Given this list of marker genes CDK2AP1, STAU2, TLCD3A (NCBI Gene Id 79850), MGAT4B, FARP1, MRAP, SNHG11, MAGEL2, FAM83D, SPATS2 (NCBI Gene Id 65244), ABCA12, POLR3D, MAZ, IDH2, MIXL1, NDUFB10, C2CD2L, TACC1, FBXL7, SLC26A11, KIF2C, MYH7, SLX4, SYT13, SMTN, NUCB2, CDCA8, GPT, GCGR, MEGF11, METRN, SSBP4, PRC1, SEMA3C, CRIP2, TTL, BEND6, PPIL1, ZG16, LSM14B, MGP, RACGAP1, PHPT1, NCAPH2, LRP5, KRT16, ZMYND11 (zinc finger MYND-type containing 11), ZC3H4, PPP1R13L, MCM10, RAB3A, AQP4, PIK3R2, ADGRA2, MAPK8IP1, CSNK1E, STARD4, CSDC2, DIP2C (disco interacting protein 2 homolog C), CORO6, GOLM2, RYK, STIMATE, TRABD, CIZ1, TACC3, INSIG1, TMED2, PLEKHG5, RCN3, MYBL2, CAV2, CDC42EP5, KIF22, MLPH, DNAJB13, MYLK3, NCOR2, FBXL19, CCNF, PTPRU, PHB2, TSSC4, NCAPD2, TMEM201, NPM1, BRPF1, SOX30, PRELID2, LRRN4CL, CTRC (NCBI Gene Id 11330), RNF126, SLC35F1, RNF168, FRMD3, CKAP2L, CDC25B, RHOJ, AMOTL1, ACBD4, PMF1, PRSS12, ST6GALNAC6, REEP3, JAM2, GAMT, CROCC (ciliary rootlet coiled-coil, rootletin), AK3, REXO1, SH2B3, SPECC1, EVC2, MAPK15, SLC27A4, ADAMTS16, GPR173, NUDT16L1, PTGR1, CERK, INO80B (NCBI Gene Id 83444), TNS2, SOCS5, LMNB2, LONRF1, TMEM59L, HSP90AA1, PCYT2, PLEKHG2, CTDNEP1, PPP2R5D, GFRA4, TOM1L2, XXYLT1 (NCBI Gene Id 152002), PTGIR, RPS8, CLDN5, PIP5K1B, MRPL39, CEP295NL, BFSP2, GPC6, LMO1, STOML3, LRRC27, RARA, ROR1 (NCBI Gene Id 4919), DLGAP5, CDCA3, GLT1D1, VEGFB, ROGDI, MSRB2, VCL, ADAMTSL5, EDIL3, CCNB2, NEU1, SCARF2, NINJ2, SAG, TIMM50, CTXN1, EIF4B (NCBI Gene Id 55378), RNF169, OSBPL6, NR1I2 (NCBI Gene Id 8856), NACA, DUSP4, CD79A (CD79a molecule), NCKAP5L, PMVK, SCD, BAHCC1, NEK2, here is a description of the gene set: studied in species Homo sapiens Human Gene Set: GSE7509_UNSTIM_VS_FCGRIIB_STIM_DC_UP Genes up-regulated in dendritic cells: untreated versus anti-FcgRIIB. The ability of dendritic cells (DCs) to activate immunity is linked to their maturation status. In prior studies we have shown that selective antibody-mediated blockade of inhibitory FcgRIIB receptor on human DCs in the presence of activating immunoglobulin (Ig) ligands leads to DC maturation and enhanced immunity to antibody-coated tumor cells. Here we show that Fcg receptor (FcgR) mediated activation of human monocytes and monocyte-derived DCs is associated with a distinct gene expression pattern, including several inflammation associated chemokines as well as type 1 interferon (IFN) response genes including the activation of signal transducer and activator of transcription 1 (STAT1). from publication Dhodapkar KM, Banerjee D, Connolly J, Kukreja A, Matayeva E, Veri MC, Ravetch JV, Steinman RM, Dhodapkar MV (PMID 17502666)